The following is a description of a gene set: species: Homo sapiens Genes predicted to be targets of miRBase v22 microRNA hsa-miR-499b-5p in miRDB v6.0 with MirTarget v4 prediction scores > 80 (high confidence targets). Human Gene Set: MIR499B_5P from publication Chen Y, Wang X (PMID 31504780), and this is the list of marker genes: BIN2, EP300, CBLN1, DTNA, PDS5B, FAM53C, RSBN1, C5orf24, TCF4 (transcription factor 4), STX7, FOXD3, FAM199X, TGFB2, PPP1R9A, PRDM10, TFCP2L1, SYNPO2, PRMT2, OLIG1, WDR37, ACIN1, FBXO40 (F-box protein 40), RHOV, TWSG1, PRPF40A, ATP5MC3, WDR77, LPP, SNX13, GLRB, NCBP2, TOE1, ITCH, AAK1, SEMA4B, VPS45, STXBP5, USP15, TET1, MRS2, PRMT6, MLXIP, KCNB1, MACO1, RASSF6 (NCBI Gene Id 166824), ASAP1, HSPH1, ISL1, ILDR2, TLCD4, C17orf75, CAMSAP2, NEK2, ATP2B3 (NCBI Gene Id 492, ATPase plasma membrane Ca2+ transporting 3), PHB1, YBEY, KMT5B, GDF15 (growth differentiation factor 15), PPP3R1, LARP4B, TLE4, MUC7, PLCB1, DLG2, TIFA, RRN3, ENO2, LRRIQ3, RNF214, FNDC3A, OPRK1, NIPA2, COPS3, JAZF1, F2R, OTUD1, AGRN, KLRC4, MAIP1, TP53INP2, SEPHS1, TDG, KIAA0586, ZFP91, TRAPPC8, LURAP1L, APBB1, TWIST1, NAPG, CSRNP3 (cysteine and serine rich nuclear protein 3), MARK3, CNOT8, GORAB, SCX (scleraxis bHLH transcription factor), UBXN7, CDK17, CHD6, TSSK4